Given this list of marker genes Col9a1, Hmga2, Stc1, Errfi1, Bmpr2, Dspp, Ltf, Bmpr1b, Slc26a2, Mmp14, Lef1, Comp, Sox9 (SRY (sex determining region Y)-box 9), Ccn2, Scube2, Ddr2, Smad7, Mustn1, Ext1, Mmp16, Npr2, Ihh, Grn, Sirt6, Golgb1, Ccn3, Six2, Pbxip1, Fosl2, here is a description of the gene set: Mouse Gene Set: GOBP_CHONDROCYTE_PROLIFERATION species: Mus musculus The multiplication or reproduction of chondrocytes by cell division, resulting in the expansion of their population. A chondrocyte is a polymorphic cell that forms cartilage.